Given this list of marker genes Fgf5, Fgf8, Fgf10, Fgfrl1, Fgf2, Fgf4, Fgf23, Fgf17, Fgf22, here is a description of the gene set: electronically inferred by orthology from the curated human pathway species: Mus musculus part of: Signaling by FGFR1 This event has been computationally inferred from an event that has been demonstrated in another species.<p>The inference is based on the homology mapping from PANTHER. Briefly, reactions for which all involved PhysicalEntities (in input, output and catalyst) have a mapped orthologue/paralogue (for complexes at least 75% of components must have a mapping) are inferred to the other species. Reactome Pathway: FGFRL1 modulation of FGFR1 signaling